Given this list of marker genes TMEM94, WDR19, MEGF8, GNB1, ALDH18A1, ATP2B1, KDELR2 (NCBI Gene Id 11014), LTBP1, LIMK1, AHDC1, DICER1, EXTL3, TCTN3, RPS6KA3 (NCBI Gene Id 6197), CBS, RAD21, TBCK, SPRED1, EMD, CDH11, TGFB2, BUD23, FBN2, PIGQ, WDR35, PDHX, GJA5, FLNA, FLNB, NSD1 (NCBI Gene Id 6797, nuclear receptor binding SET domain protein 1), RRAS2, HDAC8 (histone deacetylase 8), NEPRO, PPIB, ZEB2, FILIP1, IGBP1, KANSL1, CHST14, FHL1, SEC23B, COG4, MEGF10, B3GALT6, ADAMTSL2, EBF3, PIGL, NIPBL, FGFR1, HPGD, PCGF2, SDHD, COL3A1, PTCH1, SIK3, TRPM3, LMX1B, ZBTB20, TGDS, FBN1, MSTO1, RAF1 (NCBI Gene Id 5894), APC2, XYLT1, GDF11, SPRED2, OSGEP, EP300, MBTPS2 (membrane bound transcription factor peptidase, site 2), TBCD, PIGU, IPO8, NXN, RTL1 (NCBI Gene Id 651665), BAZ1B, POLR2A (RNA polymerase II subunit A), HSD17B4, EHMT1, MEG3, BCOR, VPS13B, COL11A2, VPS37D, KAT6A, PIGY (NCBI Gene Id 84992), ARID2, PIEZO2, NARS1, EFEMP1, CFL2 (NCBI Gene Id 1073), PACS1, SCAF4, PIGO, MGAT2, SYNE2, PIEZO1, WDR11, RFC2, GTF2IRD1, MYH3, NF1, CRELD1, CDC42BPB (NCBI Gene Id 9578), ESAM, HS2ST1, TMEM43, NRAS, NUP107, ATP7A, CD96, NFIX, SCARF2 (NCBI Gene Id 91179), SRY, SMS, SOX10, THSD4, IFT122, TGFB3, DNMT3B, HNRNPK, GTF2I, COL5A1, BICD2, TAF1, PPP1CB, SH3PXD2B, FBLN5, FBXO11 (NCBI Gene Id 80204), FGFR3, TGFBR2, DVL1, SPRTN, ZDHHC9, VPS33A, FAM20C, SMC3, KLLN (NCBI Gene Id 100144748), LIG4, TPM3, ASXL1, SMC1A, LTBP2, IGF1R, WNT5A, PLXND1, INTS1, TGFBR1, RRAS, CREBBP, CUL7, PUF60, IFT52, NPR3, PLOD1, TBX5, NCF1, FRG1, KDM6B, ROR2, SLC16A2, NSUN2, BRD4, SMAD3, INPPL1, SCN4A, MECP2, ATP6V0A2, PTEN, SDHC, NEK1, SRPX2, TMCO1, HSPG2, ITCH, BICRA, ACTA1, AP1G1, HES7, SYNE1, BMP2, PGAP2 (NCBI Gene Id 27315), SLC2A10, TUBB, LMOD3, IFT43, ITGA7, PIGW, PROKR2, DVL3 (dishevelled segment polarity protein 3), SLC37A4, EIF4H, TBL2, MAN2B1, NEB, GBA1, MET, GUSB, KRAS, CUX1, CHST11 (NCBI Gene Id 55807), IRX5, DLK1, NOG, SDHB, PUM1, B3GLCT, BRAF, AEBP1, MTX2, MYOD1, MRAS, AMER1, COL12A1, LZTR1, RIN2, PI4KA, HUWE1, CBL, FZD2, PYROXD1, WBP11, GJA8, SPECC1L, MAPRE2, SKI, PPP1R15B, KDM5C, DUX4, ACTB, MAP3K20, ELN, ADGRG1 (NCBI Gene Id 9624), PQBP1, ERF, MYF5, PYCR1, PIGT, SELENON, PIK3CA, GTF2IRD2, SMCHD1, GPC4, ERI1, TRMT10A, KLHL41, NAA10, KMT2A, GNPNAT1, FGD1, COL2A1, DDR2, MED12, FARSB, MAP3K7, EFEMP2, FKBP6, LRP4, RASA2, DYRK1A, RAB3GAP2, CHRNG, SOS2, PRR12, EFNB1 (NCBI Gene Id 1947), TRIP4, PGAP3, ANAPC7, RIT1, MAF, CRTAP, CSGALNACT1, CCBE1 (collagen and calcium binding EGF domains 1), RAB5IF, SHOC2, ABL1, IHH, MAP2K1 (mitogen-activated protein kinase kinase 1), CCDC47, TAF6 (NCBI Gene Id 6878), TPM2, NKAP, ADNP, ATG7, STX1A, UPF3B, KDM5A, SLC9A6, PPP2R1A, CHRM3, MYPN (NCBI Gene Id 84665), NOTCH3, PTPN11, FKTN, USF3, MLXIPL, SMAD2 (NCBI Gene Id 654050), COL1A2, TMEM270, SEC24D, TELO2, CA2, RBM10, DNAJC30, AKT1, METTL27 (methyltransferase like 27), HACD1, LMNA, MAP2K2, SOS1, LOX, BCORL1, GNPTAB, RET, PIGV, ZFX, DPF2, CLIP2, NHLRC2, DHODH, ASPH, GPC3, MYL2, DUX4L1, LMBRD2, ZMIZ1, MFAP5, MATN3, RNU4-2, FMR1, TRIO, KIF7, here is a description of the gene set: species: Homo sapiens Human Gene Set: HP_PECTUS_EXCAVATUM A defect of the chest wall characterized by a depression of the sternum, giving the chest (\pectus\) a caved-in (\excavatum\) appearance. Pectus excavatum